The following is a description of a gene set: species: Homo sapiens PI3K/AKT/mTOR - vitamin D3 signaling Human Gene Set: WP_PI3KAKTMTOR_VITAMIN_D3_SIGNALING, and this is the list of marker genes: CD80, IL12A, PRKAA2, PDHA1, RELA, MYC, LDHA, RXRA, CD86, HK3, HLA-DRA, AKT1, VDR, TSC2, IL10, MTOR, GSK3B, PFKFB4, CYP24A1, TSC1, SLC2A3, PIK3CA